The following is a description of a gene set: Phosphatase and tensin homologue deleted from chromosome 10 (Pten) is expressed aberrantly in non-small cell lung cancer cells, but the role of Pten in lung neoplasia has not been fully elucidated. In this study, we used a genetic approach to inactivate Pten in the bronchial epithelium of mice. Although, by itself, Pten inactivation had no discernible effect on bronchial epithelial histology, it accelerated lung tumorigenesis initiated by oncogenic K-ras, causing more rapid lethality than that induced by oncogenic K-ras alone (8 weeks versus 24 weeks of median duration of survival, respectively). Lung tumors arose in K-ras mutant, Pten-deficient mice that rapidly obstructed bronchial lumina and replaced alveolar spaces. Relative to K-ras mutant tumors, the K-ras mutant, Pten-deficient tumors exhibited more advanced histologic severity and more prominent inflammation and vascularity. Thus, Pten inactivation cooperated with oncogenic K-ras in promoting lung tumorigenesis. Cluster 4: genes down-regulated in lung tissue samples from mice with tumor-bearing genotypes (activated KRAS alone or together with inactivated PTEN). from publication Iwanaga K, Yang Y, Raso MG, Ma L, Hanna AE, Thilaganathan N, Moghaddam S, Evans CM, Li H, Cai WW, Sato M, Minna JD, Wu H, Creighton CJ, Demayo FJ, Wistuba II, Kurie JM (PMID 18281487) studied in species Mus musculus Mouse Gene Set: IWANAGA_CARCINOGENESIS_BY_KRAS_DN, and this is the list of marker genes: Cyp4b1, Plxnb1, Fgf12, Rpl22, Cyp2e1, Zscan5b (NCBI Gene Id 381986), Krtap5-1, Tmem200a, Pitpnb, 9430091E24Rik, Ddx3y, Myh6, Tmem243, Nudcd3, Capns2, Klf4, Zscan22, Myoz2, Itga1, 4930583I09Rik, Ap2a1, Galr1, ENSMUSG00000138142 (NCBI Gene Id 73791, novel transcript), Myct1, Zfp60, 4930434B07Rik (RIKEN cDNA 4930434B07 gene), Map3k14, Gria2, Alox12, Npm1, Letm1, C730036E19Rik, Parp1 (NCBI Gene Id 98479), Vps36, Itgb5, Itpripl2, Zfp612, Hdac6, Tcf4, Flt1, Itga2b, 4930523C07Rik, Arhgap5, AA467197 (NCBI Gene Id 433470), Flna, Dbp, Sp1, Dll1, Slc43a2, Pign, Fezf1, Rpgrip1, Mogs, Rexo1, Terf2ip, Limk1, Irs2, Cfd, Snrpg, Upk3bl, 5430402O13Rik, Lrp6, Cox7b2, Spag16, Art2b, Tbc1d8b, Sp3, Tbce, Zscan12, ENSMUSG00000132609, Abcb1a, Sh2b1 (NCBI Gene Id 77601), 4933400F21Rik, Nsmce2, Rcbtb2, Pik3ip1, Htr2b, Trio, Skap2, Rgs2, Itga6, Srsf1, H1f7, Hnrnpr, Rfng, Sult1a1 (NCBI Gene Id 20887), Tspan11, ENSMUSG00000136541, Scml4, Bmal2 (NCBI Gene Id 77587), Tnnc1, Itgb4 (integrin beta 4), Trim14, Pdss1, Mab21l1, Abca6, Lhfpl2, Cep70, Klrb1c, H1f2, Gnaq, Malat1, Pcdhb19, Gtpbp1, Ppp2r5c, Prkce, Safb2, Gbp2, Gtf3c5, Klf7, Pten, Nr2f2, Bmpr2, Frey1 (NCBI Gene Id 75641), Ints12, Calb1, Krcc1, Neurl1b, Spon1, Arxes1, Cadm2, Irgm2 (NCBI Gene Id 54396), Ctdsp2, Hspa12b, Fcrl1, Fibin, Plekhm2, Aktip, Eno3, Etfdh (NCBI Gene Id 99840), Madd, 7420700N18Rik, Ppp1r11, Grik4